Given this list of marker genes UCK1, IFI44L (NCBI Gene Id 10964), SIGLEC1, KIR2DS4, OAS3, FCN1, ZNF681, C2, TENT4B, KLRD1, FTL, SLC22A18, MT1F, NKG7, USP18, KIR2DL3, PTPN4, ITGB7, TULP4, ITGA5, ID2, SLX4IP, ITGAL, SPHK1, IFI27, ZNF609 (zinc finger protein 609), GZMB, HLA-J, CLSTN1, CWC15, RUNX3, PIAS1, MVB12B, CCDC8, SARAF, MT1X, TRIM41, RBM26-AS1, IFI35, BBS4 (NCBI Gene Id 585), H19, SPON2, TM9SF4, IFI44, KIAA1671, HLA-G, REC8, TSEN54, PI15, H2BC17, B2M, LUC7L2, PLEKHF1, OAS2, CHST12, DUSP2, SLC38A6, FCHSD1, CTSO, MT2A, CAPN2, HLA-F, TMBIM6, DDB2, KIF21A, RHOG, COX8A, PPCDC, SH2B2 (NCBI Gene Id 10603), GRAMD1B, CGAS, CCND3, GNLY, TMEM179B (transmembrane protein 179B), ELF1, S1PR5, RBM43, HCST, DOK2, TRIM22, IFITM1, ACTB, C1orf174, PRF1, ADGRG1 (NCBI Gene Id 9624), FDXR, STAB1, HESX1, TMEM255A, GRN, SREBF1 (sterol regulatory element binding transcription factor 1), ATG12, IKBKG, SPATS2L, MVB12A, CCL8, C1QA, EME1, EIF2AK2, C1QC (NCBI Gene Id 90369), UBC, BRD2, ZDHHC24, DNM2, ACTN4, FXYD6, RAB14, BEX5, WNT6, IFI30, RPS15, ATP6AP1, ZBP1, NRBP1 (nuclear receptor binding protein 1), CCR5, PREX1 (phosphatidylinositol-3,4,5-trisphosphate dependent Rac exchange factor 1), CYB561D2, CMTR1, SETX, TAF1C, SYNE2, LY6E, SHISA5, SLFN5, EREG, RGL1, BRD7, TRPC4AP, CD3G, HLA-B, USP30-AS1, H1-4, OGFR, SCAMP2, MAP3K11, GLG1, TAF1D, ARSA, NF1, SRGAP2, SRSF3, LGALS3BP, PLD3, P2RX4, TGS1, RADX, HLA-C, MROH8, OASL, CIDEB, NAA35, AMPD2, UBA7, NT5C3A, DDX60, GPSM3, GMIP, C1QB, SLBP, CIMAP1B, TYMP, GSTK1, GALE, PATL1, HERC6, ITM2B, LLGL2, BEST2, KIR2DL4, SHFL, ITGB2, CCL4, QSER1, UNC93B1, EPSTI1, CD84, TTYH3, ATP6V0D2, ATP6V0C, PGP, HLA-E, RGS13, OTOF, HLA-A, NR3C2, SH2D2A, ARL5A, RFPL3S (RFPL3 antisense), ESF1, PEPD, HSH2D (hematopoietic SH2 domain containing), KCTD14, TAF10, TBC1D9B, ADAR (NCBI Gene Id 3427), here is a description of the gene set: To study the transcriptional profile of patients with acute RSV or Influenza infection,children of median age 2.4 months (range 1.5-8.6) hospitalized with acute RSV and influenza virus infection were offered study enrollment after microbiologic confirmation of the diagnosis. Blood samples were collected from them within 42-72 hours of hospitalization. We excluded children with suspected or proven polymicrobial infections, with underlying chronic medical conditions (i.e congenital heart disease, renal insufficiency), with immunodeficiency, or those who received systemic steroids or other immunomodulatory therapies. The RSV cohort consisted of 51 patients with median age of 2 months (range 1.5-3.9) and the influenza cohort had 28 patients with median age of 5.5 months (range 1.4-21). Control samples were obtained from healthy children undergoing elective surgical procedures or at outpatient clinic visits. To exclude viral co-infections we performed nasopharyngeal viral cultures of all subjects. We recruited 10 control patients for the RSV cohort with median age of 6.7 months (range 5-10), and 12 control patients for the influenza cohort with median age of18.5 months (range 10.5-26). Genes down-regulated in comparison of peripheral blood mononuclear cells (PBMC) from infancts with acute RSV infection versus PBMCs from infants with acute influenza infection. species: Homo sapiens from publication Ioannidis I, McNally B, Willette M, Peeples ME, Chaussabel D, Durbin JE, Ramilo O, Mejias A, Flaño E (PMID 22398282) Human Gene Set: GSE34205_RSV_VS_FLU_INF_INFANT_PBMC_DN